The following is a description of a gene set: species: Mus musculus The process of directing proteins towards the lysosome using signals contained within the protein. Mouse Gene Set: GOBP_PROTEIN_TARGETING_TO_LYSOSOME, and this is the list of marker genes: Vps53, Nedd4, Sort1, Hgs, Ncoa4, Snx16, Lamp2, Vps4a, Hspa8, Gnptab, Ap4m1, Rab7, Vps54, Clu, Gga3, M6pr, Sorl1, Ndp, Atg14, Scarb2, Lhcgr, Zfyve16, Pik3c3, Becn1, Gcc2, Laptm5, Ap3b1, Lyset, Pik3r4